The following is a description of a gene set: from publication Travaglini KJ, Nabhan AN, Penland L, Sinha R, Gillich A, Sit RV, Chang S, Conley SD, Mori Y, Seita J, Berry GJ, Shrager JB, Metzger RJ, Kuo CS, Neff N, Weissman IL, Quake SR, Krasnow MA (PMID 33208946) studied in species Homo sapiens Human Gene Set: TRAVAGLINI_LUNG_PROLIFERATING_BASAL_CELL, and this is the list of marker genes: NRM, HIGD2A, CEP55, ALDOA, TMEM237, RPS16, MACROD1, RPL13A, CDCA4, AIP, PSMD2, MLF2, TUBA4A, EIF2S3, SLC25A6, SIVA1, PRIM1, MIR205HG (MIR205 host gene), ALKBH7, GSS, UXT, TRIM59, RPS7, OAT, PDLIM1, NAP1L1, ARL4A, STOML2, FAM3B, PRPF19, DBF4, ANP32B, BUB1, KRT5, SSRP1, SNRPA1, YEATS4, GSTZ1, NAPRT, C16orf74, EEF1G, PRDX3, MYL6B, RPS15, RACGAP1, UBE2I, EIF3D (eukaryotic translation initiation factor 3 subunit D), PRKRA, HNRNPA1, HS3ST1, MRPS15, RAN, NOB1, SLC1A5, EIF3I, KRT17, XRCC5, COPS8, PPIA, MCM7, ATXN10, CAPG, UQCRH, UQCRC1, CDK4, SERPINB4, PRRG4, UBE2C, NDUFS8, CHTF18, ARL4D, KNSTRN, TALDO1, NCL, IDH3G, PLK1, SMS, CYC1, NUDT22, NPM1, CALML3, UBA2, LMO4, F12, THOC3 (NCBI Gene Id 84321), CACYBP (NCBI Gene Id 27101), PSMD8, TK1, HNRNPD, GSTP1, RPA1, EIF3L, EIF2AK1, SERINC2, SUMO3, SMIM15, PDHA1, RPL8, PIH1D1, BARD1, PPM1G, PRPSAP1, PKM, IGFBP2, MRPL37, E2F8, SNRPD1, CCNA2, CLDN10, KIF20B, RFC5, TPGS2, RFC4, CDK1, TSEN34, MTG1, PBK, PERP, RPS15A, COQ2 (NCBI Gene Id 27235), ATP5F1D, H1-4, DDB2, CNOT2, DLEU1, TXNL1, CD82, TRIP6, TEX30, HMMR (NCBI Gene Id 3161), PA2G4, LINC03104, KIF2C, NABP2, POLR2E, ANAPC5, KCTD1, NDUFV1 (NCBI Gene Id 4723), SYTL1, TECR, RRM1, COX8A, BTF3, ARFRP1, MIS18BP1, H2AX, NDUFS3, ENO1, MCM3, C1QBP, MDK, DCTPP1, FBL, EIF2D, BRCA2, ADH7, RASSF6, METTL5, TCEAL2, HAUS4, MND1, COPS3 (COP9 signalosome subunit 3), FAM107A, PSIP1, NDUFA9, NACA, LAD1, ISOC2, APEX1, MIS18A, FANCI, MKI67, GTF3A, ADAM15, IL33, IMPDH2, BEND5, PRPS2, PTTG1, ZNF703, H2AZ2, RHOC (ras homolog family member C), SFN, TRAP1, CDC123, FAM3C, ATP5F1C, ASF1B, RPL3, BCL11A, LINC00958, CCT2, TMEM106C, GHITM, PHB1, CFL1, PSMD7, HNRNPA2B1 (heterogeneous nuclear ribonucleoprotein A2/B1), CLSPN, SERPINB13, NCAPG2, ZNF581, CARS2, PARP2, TCF4, HDAC1, SNHG5, HEBP2, GADD45A, GCHFR, FANCD2, ACBD6, SNRPG, POP7, NCAPH, NUF2, SLITRK6, TUBA1B, MDH2, LSM5 (LSM5 homolog, U6 small nuclear RNA and mRNA degradation associated), H19, DEK, NT5C, ARL6IP1, CCT6A, COMTD1, RPSA2, RNASEH2A, IP6K2, CDH3, TUBB, EPRS1, INTS10, MRPS16, FN3KRP, NHP2, PLEKHA5, MZT2B, FKBP1A, PSMB7 (proteasome 20S subunit beta 7), ZFYVE21, CENPF, POLD4, EEF2, RPL18, UBE2T, KIF11, UACA, NCAPG, MELK, TSR3, TUBA1C, LMNB2, LSM8, DCTN2, MPG, KRTCAP3, RPS4X, RPN2, S100A2, TRIP13, NDUFA10, SNRPB, RPL32, PPIG, SRSF9, AQP3, HES4, RPL11, CENPN, GOT2, TRIM7, BIRC5, ITGB4, VRK1, TIMP1, HNRNPA3, RAD51, TXNIP, CKS1B, IGBP1, PSME2, CDKN2D, TXN, CEP15, ORC6, NUCKS1, CDKN2C, ALDH3A1, RPL14, UQCRC2, NOP53, ACOT7, POLD2, SOX2, UHRF1, CHST9, RND3, CENPK, BHLHE40, MAD2L1, A4GALT, AKR7A2, FERMT1, SGO2, GPX2, RPS19, ILF2, AP2M1, CCDC34, RPL23A, HES1 (NCBI Gene Id 3280), RHOBTB3, DDIT4 (NCBI Gene Id 54541), PAICS, SCCPDH, AQP5, DCK, PSMC3, TNC, SDHAF3, HMGB2, IFI16 (NCBI Gene Id 3428), RPL7, AK2 (adenylate kinase 2), GAPDH, ISLR, HINT1, RACK1, PSMD14, AKR1B10, SNRNP25, PIK3R1, ORAI3, UCHL5, FKBP4, RPL28, TROAP, CBX3, HCAR2, GINS2, CCDC90B, PPP1CC, HMGN5, RPS2, FAM83D, PKP3, SLC25A5, NDUFB10, HNRNPR, ATP5PB, BCL2L12, TIMM10, TSHZ2, RPL4, GLUL, SERPINB3, CAMLG, RAD51AP1, SMC4, CDK2AP1, DAPL1, SYPL1, RPSA, TP53I13, CCNB1, CENPA, CDK16, CRBN, RPL19, BAG1, SMC3, DPYSL3, PARP1, ASPM, PHF19, SUMO2, FBLN1, ATAD5, INTS11, OAF, MXD3, ZDHHC12, IGFBP6 (NCBI Gene Id 3489), POLE4, POC1A, COX5A, DNMT1, RBBP7, SNRNP40, SDHA, GLRX5, TP63, POLR1D, MTHFD1, JPT1 (Jupiter microtubule associated homolog 1), MTFP1, PFN1, RASSF1, SPRY1, MMP10, GGH, UCHL3, SERPINF1, FDPS, UBE2D2, PARK7, PIMREG, RFC2 (NCBI Gene Id 5982), PABPC1, CENPH, VDAC1, TOMM5, CBR1, ATP5F1A, RPS9, RNASEH2C, ADGRG1, CHEK1, KIF4A, UBE2V2, AHCY, DSP, GJB3, SSBP1, TTK, FAM162A, PITX1, SNHG29, YWHAH, TSKU, PCNA (proliferating cell nuclear antigen), MIF, EIF3F, PTPRZ1, NPM3, KRT6A, CHCHD3, PSMA2, XRCC6, ATP5MC2, RPS18, PTN, PSMB9, DEFB1, RTRAF, ESRP1, SRM, LSM2, KIFC1, KHDRBS1, CLN6, CCNB2, NMU, GSTO1, NHERF1, RCN2, EIF4EBP1, EIF3E, HMGB1, UBA52, GPN3, TPX2, CENPU, PDCD4, WASF2, GMNN, SNAI2, ESCO2, MARCKS (myristoylated alanine rich protein kinase C substrate), RAB13, MRPS26, CKS2, HMGN2, PSMD4, NUDT21, CENPW, ATAD2, PPP5C, EIF3K, HMGA1, KIF22, SLC2A1, UBE2S, GSTM4, NUSAP1, RPL6, CENPE, SLC25A11, FAM111A, LMNB1, VDAC3, COX6B1, VDAC2, ATP5MC1, SLC25A39, RPL10A, CAPN1, SUPT16H, PDIA6, KARS1, NCOR1, CHEK2, FMO2, CDC6, PSMC4, ATP5PO, CCT3, NAA10, MACROH2A2, KIF20A, RPS27A, RPL7A, DIAPH3, ECI1, FIBP, MRPL12, ADRM1, RAB34, RPLP0, PIGT, AGR2, KRT14, SOX15, KIF23, ADSL, DUT, LAGE3, LY6E (NCBI Gene Id 7999), TMEM14A, NCAPD3, PDHB, TMEM54 (NCBI Gene Id 113452), OXA1L (NCBI Gene Id 5018), CDKN3, TREX1, PRSS23, CHCHD10 (coiled-coil-helix-coiled-coil-helix domain containing 10), MGME1, VPS29, MDH1, SERPINB5, CSE1L, CLEC2B, CLPTM1, PTGES3, CENPM, DANCR, HDAC2, PAFAH1B3, CBX5, RWDD1, ANP32E, RNASEH2B, ARPC1A, HTATSF1, FHL2, BCL7C, RHEB, HAUS1, HP1BP3, NDUFS2, SF3A2, GLTP, TERF1, UGP2, AKR1A1, STMN1, ANLN, FEN1, ACP1, METTL23, UQCC2, GUSB, TKT, FXYD5, ATP5F1B, RPS12, MSH2, RPL10, LSM4, TP53, KRT19, JUP, IGFBP4, RPS3A, TCP1, CSTA, HNRNPAB, PTMA, NASP, HELLS, UBE2E3, ESD, BUB1B, S100A16, P4HB, TNFSF10, SNHG32, TMEM123, PFKL, BAZ1B, METTL9, ETFB, RCC2, TPRKB, SHMT2, EXOSC8, PSMG2, HMGN1, PCLAF, HJURP, NDUFB5, MPC2, SMC1A, PXMP2, GPAA1, CKMT1B, TOP2A, PHGDH, MEA1, RPS6, CDCA2, PSME1, PCBP2, CDCA3, CYBA, TSPO, MAD2L2 (NCBI Gene Id 10459), NFIA, HSPB1, PPIH (peptidylprolyl isomerase H), HSD17B10, NAP1L4, ZNF43, POLR2G, HADH, CD320, CCT4, NONO, HSPA9, TCF19, PYCARD, MTCH1, SUCLG1, PKP1, ECT2, MCM6, LGALS7B, H2AZ1, EIF3M (eukaryotic translation initiation factor 3 subunit M), LSM3, RAD21, HEXB, TACC3, BUB3, MKKS, TIMMDC1, IDH2, TACSTD2, LINC01133, ADH1C, PPP1R14B, STRAP, FOXN3, NUP37, PKMYT1, NUDT1, SULT2B1, S100A14, PRXL2A, ITGB3BP, RAD51C, ARHGAP11A, PHF20L1, ACAT2, ATP5MC3, ADISSP, RPL13, CCT5, EZH2, SMC2, LARP6 (NCBI Gene Id 55323), STAT1, POSTN, DHFR, USP1, PSMB8, HRAS, COMMD4, YBX1, UPK1B, TYMSOS, SNRPF, ABRACL, FKBP5, ANAPC11, IKBIP, RMI2, RPL15, NEK2, COA8 (cytochrome c oxidase assembly factor 8), LY6D, AURKA, KRT13, MGST2, UBAC1, MMAB, DLK2, TYMS, SNRPE, CYP2S1, NDC80, GPSM2, H1-3, DDX39A, H1-5, AP2S1, DLGAP5, KNL1, PRKDC, PTGR1, RCC1, GPC1, NDUFB9, SAC3D1, GAS5, UFD1, FAM111B, H1-1, TMPO, EEF1D, MRPL51, TFDP1, POLR1E, RBM3, RPL39L, ITGB1BP1, SGO1, ST6GALNAC1, TPI1, SMARCC1, RPL29, HSPD1, MRPL18 (NCBI Gene Id 96273), PAGR1, EIF4H, PPP1CA, ALOX15, KRT15 (keratin 15), LIME1, UPF3A, PRPF38B, FAM3D, CDCA5, TPR, GTSE1, ALDH7A1, ISYNA1, PPP1R13L, CLCA2, TUFM, TPM2, KRT16, ZWINT (NCBI Gene Id 11130), SPC25, SRP9, RRM2, LRRCC1, PAXX, CALD1, MRPL13, HADHB, ABHD16A, DGCR6L, SNCA (NCBI Gene Id 6622), NME1, MTFR2, SLC25A3, REEP4, SLBP, RHNO1, SAE1, IGFBP3, COX7B, CDCA7L, SNRPA, CENPS, MACROH2A1, CLNS1A (chloride nucleotide-sensitive channel 1A), COX4I1, OLA1 (NCBI Gene Id 89690), C1orf35, SKA2, TUBG1, CARHSP1, HMGB3, AVPI1, RUSC1, PRC1, HADHA, DKC1, PRDX2, SNHG7, EEF1B2, DTYMK, LDHB, GRHPR, SUN2, ETFA, RPS3, SEC11A, MRPL28, RPS17, GGCT, ETHE1, RPLP1, MZT1, CDC20, RPS23, NUDT8, CCT7, DNAJC8, LMF2, NCAPD2, MZT2A, EXOSC3, PSMB1, FABP5, PHB2, DNAJC9, ABT1, ATP1B3, AGGF1, AURKB, GOT1, CKAP2, MCM5, SRSF2, CKAP2L, IMMT, UQCC3, CSNK2B, TSC22D3, ARPC2, PGAM1, NOP56, RANBP1, TRIM29, GYPC, TMX1, BUD13, HNRNPUL1, PDCD5, TEX264, CDT1, EEF1A1, HEY1, GDI2, PLP2, CXCL14, DSC3 (NCBI Gene Id 1825), C19orf48P, RPS5, TOMM40, ECHS1, FGFBP1, BSG, CMAS, FKBP3, RPS8, RPL26, CDC45, GNAI1, YWHAQ, MRPL21, DEPDC1, PCMT1, SNF8, KIF21A, SRSF3 (NCBI Gene Id 6428), H4C3, MRPL11, MTERF3, TOMM22, PRMT1, KPNA2, RAP1B, FOXM1, RPL18A, NSG1